Given this list of marker genes INO80D, RNASEH1-DT, MPHOSPH10, ZFP90, UBFD1, NUDT9, MGP, ZNF271P, JAGN1, PRKD1 (NCBI Gene Id 5587), VSTM4, DHX8, ZNF75A, FAM133B, NOL9, SALL4, ARL17A, PHC1, MORN2, DHX35, RTF2, BOC, TSPAN6, ITGB5, CTCF, SNED1, MRPS35, KAT14, MRPL44, CSTPP1, MGA, RBBP6 (RB binding protein 6, ubiquitin ligase), THOC2, COPS8, ERVK3-1, MFAP3L, E2F6, STAG2, AHI1, NDUFAF7 (NCBI Gene Id 55471), LMLN, BBS9, SLC11A2, IPO8, GPRASP2, ACP1, EMC1, ZNF449, PPWD1, DTX3, CREB1, SLC25A33, SCFD2, ATP9A, MMGT1, MARVELD2, SEC62, MAGEE1, EPC2, ZNF711, CKAP5, ISCA2, GIHCG, CBFA2T2, LAMA2, SLC16A10, TCTN3, BORCS5, VBP1, AMZ2, DIS3L2, TMEM128, FAM13B, UPF3B, SVIP, RETREG2, HSD17B12, FASTKD2, GAS7, ATXN3, RAD17, VKORC1L1, LCLAT1, INO80D-AS1, TMEM201, MTERF4, MRPL1, C2CD5, B4GAT1 (beta-1,4-glucuronyltransferase 1), SMIM10L1, PRCP, MPDZ, QPCT, EPM2AIP1, BDH2, ZFHX3-AS1, CHST10, DPY30, ASB3, B4GALT5, SPEN-AS1, CCT6P3, ALDH6A1, LRP6 (NCBI Gene Id 4040), DYRK4, PLCB4, ALS2, COX11, NKAP, CNPY2, GEM, HNRNPH1, NAT9, METTL21A, MEST, MTERF2, TAF1C, ATAD2B, SFMBT1, MAGI2, FAM161A (FAM161 centrosomal protein A), RNF32-DT, HEBP1, ZNF397, CENPBD1P, SLC25A14, SALL2, ARMCX3, DNAJC18, ERCC8, TXNDC15, HJURP, SNF8, DCUN1D1, WDR12, ZNF26, EFHD1, PRR3, RXYLT1, GLRX5, DNAJB11, BOLA1, CCNB1IP1, ANKRD40, LAMTOR5-AS1, PDIA4, H2BC8, ZSCAN26, TCEAL4, HNRNPUL2, CETN2, NCL, TCEAL8, FARP2, LRP4, FAM229B, DYRK2 (dual specificity tyrosine phosphorylation regulated kinase 2), PDXDC1, TMX4, PAIP2B, CENPS, TP53BP1, AGFG1, CCP110 (centriolar coiled-coil protein 110), MTHFSD, FIP1L1, ACACB, ST13, GCAT, SEPHS2, ZNF621, EEF1B2, PILRB, PSMD1, NMT1, SPATA7, MTNAP1, VHL, SENP2 (SUMO specific peptidase 2), ATRX, SLC22A17, CAND2, ZNF24, DNAL1, GIGYF2, ABCD4, SLC37A3, SUMO1, PABPN1, KAT8, NAT10, TTLL5, ARMCX1, GPR89B, RPL22 (ribosomal protein L22), CDCA3, ARL16, BBOF1, TTC17, RPL13P5, TIGD1 (NCBI Gene Id 200765), RPE, SMARCA1, NUDT7 (nudix hydrolase 7), APOOL, BEX3, GXYLT2, PKP4, SNHG14 (small nucleolar RNA host gene 14), ADAMTS9, ZMYND11, SRSF6, PLEKHA5, TPST1, ZNF764, ACVR1B, PXDN, TMED8, APPBP2, ZNF92, MAGEF1, FRZB, LMTK2, ELP2, TMLHE, MOB1B, PAPOLA, EP400, TIGD7, ZBTB33, PDRG1, BEX4, GGT7 (gamma-glutamyltransferase 7), PMS2 (NCBI Gene Id 91271), GPR19, NUDT4, APBA2, LMAN2L, NUP54, GABARAPL1, PHB1, ZNF704, ZMYM3, ABCB7, RBM25, ABI2, PPIG, USP13, ACVR2A, NUP107, C14orf132, CCDC43 (coiled-coil domain containing 43), SH3BGRL2, RBM15, DDR2, WDCP, DTX4, TRIP12, ZNF606, NOP58, TAFA5, LGR6, MTA3, GPRC5B, PARL, RASL12, ETV4, ILKAP, EDAR, RLIM, FGF19, NAP1L5, LINC02893, ITGA9, MFF, ZBTB14, PDZD11, APOLD1, MSL2, MUTYH, TFDP2, GNAS, HIRIP3, TMEM18, SH3RF3, NEPRO, ETV5, SDAD1, IFT43, RNF25, YIPF6, RASSF8, AKAP1, PNN, MSH5, BEX5, FAM234B, TMT1B (NCBI Gene Id 196410), C18orf21, PFKM, SNHG33, BEX2, PSMD10, BEX1, NBR1, BUD23, OSCP1, LNP1, CADM1, CDK5RAP3, SHE, C1orf56, YTHDC1, GATC, ARMCX6, TAF9B, BEND7, CYB5RL, ANG, TMEM97, DDIT3, SEC14L4, EFCAB11, LRRC23, IDH1, TTC5, USP51, VPS45, JAM3, ITGBL1, YARS2, TFAM, IFT52, PASK, NEK9, MECP2, HSD17B11, NDUFS1, RBMX2, ZNF133, PPM1D, ZNF789, PGRMC1, ADAM17, CAND1, MAGEH1, GPRASP3, SUPT7L, ZNF263, MDM1, here is a description of the gene set: Genes up-regulated in metastatic vs non-metastatic HNSCC (head and neck squamous cell carcinoma) samples. Human Gene Set: RICKMAN_METASTASIS_UP from publication Rickman DS, Millon R, De Reynies A, Thomas E, Wasylyk C, Muller D, Abecassis J, Wasylyk B (PMID 18679425) Propensity for subsequent distant metastasis in head and neck squamous-cell carcinoma (HNSCC) was analysed using 186 primary tumours from patients initially treated by surgery that developed (M) or did not develop (NM) metastases as the first recurrent event. Transcriptome (Affymetrix HGU133_Plus2, QRT-PCR) and array-comparative genomic hybridization data were collected. Non-supervised hierarchical clustering based on Affymetrix data distinguished tumours differing in pathological differentiation, and identified associated functional changes. Propensity for metastasis was not associated with these subgroups. Using QRT-PCR data we identified a four-gene model (PSMD10, HSD17B12, FLOT2 and KRT17) that predicts M/NM status with 77% success in a separate 79-sample validation group of HNSCC samples. This prediction is independent of clinical criteria (age, lymph node status, stage, differentiation and localization). The most significantly altered transcripts in M versus NM were significantly associated to metastasis-related functions, including adhesion, mobility and cell survival. Several genomic modifications were significantly associated with M/NM status (most notably gains at 4q11-22 and Xq12-28; losses at 11q14-24 and 17q11 losses) and partly linked to transcription modifications. This work yields a basis for the development of prognostic molecular signatures, markers and therapeutic targets for HNSCC metastasis. species: Homo sapiens